The following is a description of a gene set: from publication Egawa T, Littman DR (PMID 21873191) Human Gene Set: GSE31082_DP_VS_CD4_SP_THYMOCYTE_UP Mouse thymocytes can be classified into four major subsets based on expression of CD4 and CD8 co-receptors. CD4-CD8- (double negative, DN) cells become CD4+CD8+ (double positive, DP) cells following productive T cell receptor (TCR) beta chain rearrangement. A small proportion of DP cells are selected through interaction of clonal TCRalpha/beta and MHC self peptide complex expressed on thymic stromal cells. DP cell expressing MHC class I-restricted TCR become CD4-CD8+ cells, which will finally differentiate into cytotoxic T cells, while MHC class II restricted selection generates CD4+CD8- helper lineage T cells. We used microarrays to identify genes important for thymocyte differentiation and lineage determination by profiling gene expression in different thymocyte subsets. Genes up-regulated in comparison of CD4+ CD8+ thymocytes versus CD4+ CD8- thymocytes. studied in species Homo sapiens, and this is the list of marker genes: FAM241A, PLA2G12A, ATP5F1B, RAB21, SMC4, TENM1, ANGPT1 (NCBI Gene Id 284), GZF1, UHRF2, GINS1, CHCHD7, PAIP2, LSM14B, PAGR1, PARPBP (PARP1 binding protein), RPA1, BRD9, PTPN14, POLR2I, TRAK1, CDCA2, STRN, UBE2E3, TTC12, UBALD2, CNOT8, HMGB2, ALYREF, RASL11B, FCHO1, IFT52 (intraflagellar transport 52), KIAA1958, CTDSPL2, CIBAR1, CMC2 (NCBI Gene Id 56942), LCK, LRWD1, MACIR, SRGAP2, PRKCI, CDKN2AIPNL, PCBP3 (poly(rC) binding protein 3), CST3, ATP5F1A, LAG3, CKAP5, SLC38A1, EXO1, ATP6AP2, BRD8, TBC1D22A, NETO2, SOS2, RTKN2, NDUFB6, EEFSEC, RAB12, EIF1AX, CENPC, ACADM, FEM1B, PRPF40A, SDHD, SMC5, ING4, BRCC3, GSTM5, SDC4, MDM1, H2BC13, DIP2A, PWWP4, RP9, CDKL1, SMC3, SLMAP, KRAS (KRAS proto-oncogene, GTPase), MEX3C, USP15, DOHH, GDPD1, SLC30A4, OAZ1, POLA1, CCP110, GABPB1, CASS4, DTYMK, TMEM263, METAP2, WDR27, SPRTN, EMID1, HDLBP, KCNK5, PGPEP1, STRN3 (striatin 3), UMAD1, CIPC, MRPL51, HNRNPH3, OSBPL11 (NCBI Gene Id 95889), SANBR, PRDX2, GTF2A2, TCEAL9, CTDSP2, RAPGEF1, ZNF841, BRPF3, DCTN1, SCAI, BMF (NCBI Gene Id 90427), MED30, CTC1, MRPL3, MRPS11, CREB3L2, FADS1, ANKHD1, JADE3, TRPS1, SMARCD2, UBE2A, MRFAP1L1, POC1A, CLDN4, TUBB, DDIAS, PGLS, THEM6, NELFB, WDR83 (NCBI Gene Id 84292), STXBP5, EIF4E3, INPP5K, PPIL2, LYNX1, PPP1CC, SLC35E3, CDK2AP1, IGIP, UHRF1, VPS36, KIF5B (kinesin family member 5B), HCCS, NXN, ZC3HC1, AGPAT5 (1-acylglycerol-3-phosphate O-acyltransferase 5), TRIM39, TRIM11, HAUS8, PCGF3, MXD3, CEP89, KATNIP, SEC11C, ZBTB33, KDM3B, MOB1B, UQCR11, NKAP, TEDC1, CCT7, H2AZ1, AAGAB, EHMT2, CEP57, CKAP2, RANBP3, DYNLRB1, HELLS, C5orf24, ZNF653, SKA1, BAD, SCNM1, TBC1D25, MLF2, TUBG1, SETD4, ZNF24, ACADL, SLC43A2, ANKRD40, RFC4, ELOA, ERCC6L, COX17, PDPK1, TP53INP2, CEP19, CBLL1, SBNO2, COX6A1, PHC1, AUH, PSRC1, TRIM37